The following is a description of a gene set: Human Gene Set: GSE3982_MAC_VS_NEUTROPHIL_LPS_STIM_DN In the present study we used Affymetrix oligonucleotide microarrays to produce gene transcription profiles for the major leukocyte types in humans. This comprehensive dataset enabled us to not only establish which genes were expressed in each leukocyte type, but also which genes were expressed in each subset after activation. The used of a comprehensive dataset of gene profiles from all the major human leukocyte subsets enabled a novel and powerful means for identification of genes associated with single leukocyte subsets, or different immune paradigms. species: Homo sapiens Genes down-regulated in comparison of macrophages stimulated with LPS (TLR4 agonist) at 4 h versus neutrophils stimulated with LPS (TLR4 agonist) at 1 h. from publication Jeffrey KL, Brummer T, Rolph MS, Liu SM, Callejas NA, Grumont RJ, Gillieron C, Mackay F, Grey S, Camps M, Rommel C, Gerondakis SD, Mackay CR (PMID 16474395), and this is the list of marker genes: SH3D21, ADAMTS13, KPNB1, P2RY4, AQP8, SLC7A9, CIB1, SECISBP2, SLC45A2, ATG3, CHST8, PPP1R14B, FICD, LRRC3, UBE2B, MARCKSL1 (NCBI Gene Id 65108), ZNF669, NOMO3, DCAF4, PRRX2 (NCBI Gene Id 51450), IL22 (NCBI Gene Id 57328), CHRND, LUC7L2, PPP1R11, KLF12, IST1, GML, CXCR2, TRBC1, HPR, SLC3A1, MICAL1 (microtubule associated monooxygenase, calponin and LIM domain containing 1), NOP14-AS1, JMJD1C, GRM4 (glutamate metabotropic receptor 4), DPY19L1P1, CCN2, POLR2C, FRAT2, H4C1, CROCC, CYP2A13, ALOX5AP, LIMD2, PCNX1, ZNF639, SLITRK5, FOSL1, BAZ2B, SFTPA2, NYX, ERCC6, H4C6, RCOR1, ZNF552, TMEM177, MAB21L4, FGF4, SLC1A6, SLC38A7, RUBCNL, HRH2, RALB, STEAP4, KIR2DL4 (killer cell immunoglobulin like receptor, two Ig domains and long cytoplasmic tail 4), TAF7, RALBP1, HSPB6, TLR5, NMNAT2, IFNG, CCDC69, TMUB2, NPTX1, LCP2, ZNF467, MAP2K3, CNN2, SLC6A14, USH2A, ENTPD1, ARF4, BDKRB1, CALD1, TRIM33, BTG2, HTR5A, AFF2, XPO6, ITM2B, H2BC21, ALAS2, DGKQ, U2AF1, PLA2G2D, DPF1, CD1D, ABCF1, RIC8A, TROAP, POSTN, EPHB3, VAMP2 (NCBI Gene Id 6844), PLEKHJ1, ARC, ANXA3 (annexin A3), SEC14L3, BCL2L10, SOX11, ZBTB18, AREL1, EXD3, E2F2, GAB2, TINF2, S100A12 (S100 calcium binding protein A12), DOC2B, ZFYVE9, NECAP1, PEF1, SFI1, CD93, SLC8A2, LHX5, GRP, PAH, USP4, APEX2, TSPAN32, MEGF9, IER2, TP53I11, POLR1G, LMBR1L, OR2F2, HPX, MGRN1, TMA7, VNN1, BCAM, PACS1, NTSR2, JMJD6, IKZF5, RIMBP2, AKAP4 (A-kinase anchoring protein 4), RESF1, GUSBP11, SLC12A3, MPP2, EFHD2, ELAVL3, CYFIP2, HGF, MAP3K10, WDR1, ZNF362, HMGA2 (high mobility group AT-hook 2), ODF2, SPATA2L, OR2W1, TLE1, IGFBP5, MGAT4A (NCBI Gene Id 11320), PSMD13, ITPK1, H3C11 (NCBI Gene Id 8354), HAPLN1, EXTL1, F2RL1 (NCBI Gene Id 7901), KCTD20, LIN28A, DNAJC4 (NCBI Gene Id 93087), SLC7A4, TCF7, MTMR3, HDAC7, CTSG, ART1 (NCBI Gene Id 417), PTPRN2, LRP10, ZDHHC18, RALY, SIKE1, TCF25, PTH2R, FUT6, EHD1, PRPS1L1, LRRC37A3, TPSB2, PTTG1IP, UBOX5, LZTR1, SRPK3